Given this list of marker genes LIG3, XRCC1, APEX1, POLB, here is a description of the gene set: studied in species Homo sapiens Reactome Pathway: Resolution of AP sites via the single-nucleotide replacement pathway The single nucleotide replacement pathway of base excision repair appears to facilitate the repair of most damaged bases. Following DNA glycosylase mediated cleavage of the damaged base, the endonuclease APEX1 is recruited to the site of damage where it cleaves the 5' side of the abasic (AP) deoxyribose residue. DNA polymerase beta (POLB) then cleaves the 3' side of the AP sugar phosphate, thus excising the AP residue. APEX1 is subsequently released, the XRCC1:LIG3 complex is recruited, and POLB mediates the synthesis of the replacement residue. Following LIG3 mediated ligation of the replaced residue, the XRCC1:LIG3 complex dissociates from DNA. An alternative BER pathway is employed when the structure of the terminal sugar phosphate is such that it cannot be cleaved by the AP lyase activity of POLB. part of: Resolution of Abasic Sites (AP sites)